Given this list of marker genes ALDOB, PIP4P1, TMEM199, TM9SF4, ATP6V1B1, TMEM9, VMA21, CCDC115 (coiled-coil domain containing 115), here is a description of the gene set: Human Gene Set: GOBP_PROTON_TRANSPORTING_V_TYPE_ATPASE_COMPLEX_ASSEMBLY species: Homo sapiens The aggregation, arrangement and bonding together of a proton-transporting V-type ATPase complex, proton-transporting two-sector ATPase complex that couples ATP hydrolysis to the transport of protons across a concentration gradient.